Given this list of marker genes EPG5, TSC22D3, ZFP36, ILDR2, TMOD3, CRISPLD1, DOCK11, PRDX1, KLHL10, RHEX, ZNF16, TNFAIP3, PKNOX1 (PBX/knotted 1 homeobox 1), POC1B, RRN3, STAT1, EXT1, P4HTM, TGFB2, RCOR1, NLRP6, TCEA1, RPS24, LYAR, MAEA, HMOX1, UBAP2L, LIPA, IL2RA, HCAR2, ADAR, UBA5, SLC46A2, DNASE2, FADD (NCBI Gene Id 8772), GNAT2, DIAPH3, KMT2A, BAK1, SPTA1, BRINP1, PLA2G10, NFKBIZ, VPS54, BAP1, P2RY14, RPS17, CCNB2, FOSL2, G6PD, F2R, L3MBTL3, HMGB2, NF1, IL7, SOX4, SP3, KLF1, DNAJA3, TCIRG1, TMEM63B, RHAG, ARMCX5-GPRASP2, CCR2, GPR183 (G protein-coupled receptor 183), NOS3, TGFBR3, KIT, TMEM14C, NAPEPLD, TNFRSF17, SH2B3, PRDM14, CHST3, FAM3D, HIPK2, IKBKG, GPI, RPS19, SOD1, KCNQ1, PACS1, VPS13A (vacuolar protein sorting 13 homolog A), LDB1, LGR4, GATA3, PTBP3, ADA, SEPTIN4, MUC2, JAK2, ZBTB7A, MTCH2, RC3H2, WDR48, OCIAD2 (OCIA domain containing 2), FLVCR1, ITPKB, TRAF3IP2, LPCAT3, JMJD6, SELENOW, CCN3, CHMP5, MIR17HG, TSPAN9 (NCBI Gene Id 83441), SART3 (NCBI Gene Id 9733), SPRR2A, MAPK14, INHA, COL14A1, B2M, ACVR1B, SLC4A1, EPAS1, ARMCX1, RAC3, PDE4B, SMAP1, ARNT, FSTL1, GBA1, UFL1, ELP6, SOX9, TSPO2, ARID4A, CX3CR1, SIVA1, WDR37, NCSTN, CD74, ACIN1, RAC2, PTPN11, MEF2C (NCBI Gene Id 4208), JAM3, XIAP, ETS1, GIGYF2, ALAS1, CARD11, XKR8, SMAD5, MPIG6B, FOXA3, SLC15A4, EMX1 (NCBI Gene Id 2016), FAM210B (NCBI Gene Id 81895), MED1, EPB42, SENP1, TNFSF13B, AIM2, ZC3H8, FCAR, ISG15, SLC7A11, FOXN1 (NCBI Gene Id 8456), ZNHIT1, ST6GALNAC1, IL20RB, MFHAS1, IREB2, MYB, IL2, CCR4, BCR (BCR activator of RhoGEF and GTPase), FOXO3, SIT1, BBS4, SLC40A1, SPNS2, KITLG, SMO, TNFSF14, MIR221, ARSG, MPL, ARHGEF5, HOXA5, MB, TRIM10, CEBPG, HDAC6, CARD9, PRDX2, MAPK11, PPP2R3C, TAL1, LGALS9, HMGB1, KMT2E, SLC48A1, BPGM, DOCK10 (NCBI Gene Id 9714), DYRK3, YPEL4, COL6A1, ID2, ADGRG1, MYCT1, RB1, SLC25A5, PPP3CB, JAK3, NFE2L1, CITED2, ETV2, TRIM58, SASH3, NCAPG2, ABCB10, RIPK3, ZFPM1, KLF2, SFXN1, PIANP, PPP2R1A, ZFY, NOTCH1, MIF, LGALS2, NKX2-3, BCL10, GPR15LG, ERCC2, LMO1, SLC25A40, FANCE, AHSP, MERTK, VEGFA, HNRNPU, BCL2, FOXP3, FBXO21, MINAR2, AKT1, PIK3CD, EMCN, SLC25A38, RPA1, NCKAP1L, AXL, BAX, TUBA1A, SLC1A5, NEMP1, PLA2G2A, CDK6, LYN (NCBI Gene Id 4067), IKZF1, BBIP1, PTH, KLF13 (NCBI Gene Id 51621), CSF1, SOS2, ASXL1, SLC11A2, SCNN1B, CORO1A, AFP, GLIS2, DMTN, FAS, GCNT4, EPO, HSCB, GPRASP2, SLC39A3, GPAM (glycerol-3-phosphate acyltransferase, mitochondrial), GLUL, NOD2, IL7R, RAC1, P2RX7, PKN1, HSPA9, HEATR3, STAT5A, FECH, POLB, MAFB, RAG1, INHBA, CAMLG, PRMT1, STAT3, ACVR2A, CDH2, BCL2L11 (NCBI Gene Id 150819), GPR174, SKIL, NLE1, HCLS1, LAT, ZNF251, GATA1 (GATA binding protein 1), MTHFD1, EZH2, ANKRD54, RACGAP1, PRKDC, BRD1 (bromodomain containing 1), RASSF2, STAT5B, FH, TGFB1, HSPA1A, LRRC19, CDIN1, FLT3, PIK3CB, ODAD3, ANXA1, CDK5RAP3, HBZ, CADPS2, SPI1, KAT7, INPP5D, ZFP36L1, CYLD, CCR7, PMAIP1, PRDX5, ATP5IF1, HOXB6, ALAS2, ABL1, ADAM17, AP3B1, SH2B2, RC3H1, PTPN2, PPP2CA, BCL6, GATA2 (NCBI Gene Id 84724), AKT3, MIR222, ADGRF5, BMP4, OCIAD1, SOS1, RPS14 (NCBI Gene Id 6208), GAPT, SRF, HIF1A, CXCL6, FCER1G, BLOC1S6, TNFRSF13B, CASP3, KRAS, BTK, THRA, IL6, HSPA1B, MIR486-1, here is a description of the gene set: species: Homo sapiens Human Gene Set: GOBP_HOMEOSTASIS_OF_NUMBER_OF_CELLS Any biological process involved in the maintenance of the steady-state number of cells within a population of cells.